The following is a description of a gene set: studied in species Mus musculus Genes predicted to be targets of miRBase v22 microRNA mmu_miR_486a_5p, mmu_miR_486b_5p in miRDB v6.0 with MirTarget v4 prediction scores > 80 (high confidence targets). from publication Chen Y, Wang X (PMID 31504780) Mouse Gene Set: MIR_486A_5P_MIR_486B_5P, and this is the list of marker genes: Baiap2l1, Pirt, Arhgap44, Dock3, Slain2, Ptpn7 (protein tyrosine phosphatase, non-receptor type 7), Cdh7, Zfp1009, Celf2, Mark1, Gria2, Cadm1, Cops7b (NCBI Gene Id 27992), S1pr3, Mtrex, Ldha, Agbl5, Draxin, Abhd17b, Dcc, Naa15, Osbpl8, Bahcc1, Pcdh15, Glis1, Snrpd1, Gsc, Tceal6, Gabra1, Gpr153, Tob1, Rin1, Slc12a5, Gab2, Il1a, Chrac1, Sp5, Col13a1 (collagen, type XIII, alpha 1), Fgf13, Polr1f, Gabrb3, Pik3r1, Nipbl, Igf1r, Tceal3, Exoc3, Foxp1, Lrrc61, Dlx3, Slc25a32, Smoc1, Rpgrip1l (Rpgrip1-like), Prrc2c, Neurod6, Emid1, Srsf3, Adgrg3, Klhl14, Epha5, Pten, Unc5c, Yipf5